Given this list of marker genes STMP1 (NCBI Gene Id 649778), TEAD1, FRMD5, SDC2, RAB8A, PFN2, HLA-DPB1, LCMT2, SPRED1, GAN, STAU1, ATXN3L, ATXN1, TOP1, C1orf56, CEP170, PHIP, MAP3K13, PPIL3 (peptidylprolyl isomerase like 3), YOD1, IMPACT, NDUFV3, SUPT3H, PHTF2, INA, EFHC2, LNX2, OSBPL6, FPR3, CTXN3, NEUROD4, TMEM165, GRM6, DCAF5, SMCO3, SLC25A40, CLDN18, PROSER1, DHRSX, here is a description of the gene set: Genes predicted to be targets of miRBase v22 microRNA hsa-miR-4781-3p in miRDB v6.0 with MirTarget v4 prediction scores > 80 (high confidence targets). studied in species Homo sapiens Human Gene Set: MIR4781_3P from publication Chen Y, Wang X (PMID 31504780)